Given this list of marker genes Ccr7, Tlr8, Panx1, Egr1 (NCBI Gene Id 13653), Pycard, Tlr6, Smad3, Il16, Gbp5, Tnf, S100a13, Hmgb1, Lilra5, Ifi203, Ifnar1, Tmem106a, Casp1, Hspb1, Tlr2 (NCBI Gene Id 24088), Ccl19, Jak2 (Janus kinase 2), Wnt5a, Malt1, Rela, Ifi207, Stmp1, Gsdmd, Nlrp10, Casp4, Nlrp1b, Lpl, Cd36, Ccn1, Ifi214, Mndal, Ifi206, Hdac2, Nlrp1a, Gsdma3, Ccl20, Nod2, Inava, Mefv, Stat3, Tyrobp, Aim2, Ifi208, Casp8, Il17a, Lgals9, Havcr2 (hepatitis A virus cellular receptor 2), Tlr4, Nod1, Ighd, Naip5, Ccl3, Fzd5, Ager, Hk1, Panx2, Ifi203-ps, Ccr5, Ifi209, Nlrp3, Panx3, Ripk2, Ifi213 (interferon activated gene 213), App, Nlrc4, Usp50, Il6, Ifng, Tmed10, Myd88, Isl1, Tmed10-ps, F2rl1, Clec7a (C-type lectin domain family 7, member a), P2rx7, here is a description of the gene set: Any process that activates or increases the frequency, rate, or extent of interleukin-1 production. studied in species Mus musculus Mouse Gene Set: GOBP_POSITIVE_REGULATION_OF_INTERLEUKIN_1_PRODUCTION